Given this list of marker genes Tbx18, Gata6, Ppard, Malat1, Atf2, Pax7, Igf1, Kcna5, Fgf7, Sox15, Csf1r, Six1, Fgfbp1, Paxbp1, Snhg15, Meis2, Megf10, Ctnnb1, here is a description of the gene set: Any process that activates or increases the frequency, rate or extent of myoblast proliferation. Mouse Gene Set: GOBP_POSITIVE_REGULATION_OF_MYOBLAST_PROLIFERATION species: Mus musculus